The following is a description of a gene set: Human Gene Set: GOCC_PCG_PROTEIN_COMPLEX A chromatin-associated multiprotein complex containing Polycomb Group proteins. In Drosophila, Polycomb group proteins are involved in the long-term maintenance of gene repression, and PcG protein complexes associate with Polycomb group response elements (PREs) in target genes to regulate higher-order chromatin structure. studied in species Homo sapiens, and this is the list of marker genes: RNF2, SIRT1, RBBP4, ASXL2, CSNK2A2, ZFP42, BAP1, UBAP2L, ASXL1, PCGF3, CBX4, EZH2, YY2, CBX2, PHF1, EPOP, AEBP2, JARID2, BMI1, PHF19, PHC1, EZH1, CBX7, PCGF6, PCGF2, SKP1, RING1, CSNK2A1, RBBP7, CBX6, MTF2, HDAC2, PHC2, SUZ12, PCGF5, EED, SAMD11, CBX8, SAMD7, DNMT3L, YY1, KDM2B, ASXL3, RYBP, CSNK2B, PCGF1, PHC3, SCML2, TRIM37 (tripartite motif containing 37)